The following is a description of a gene set: species: Mus musculus Catalysis of the reactions: D-myo-inositol 1,4,5-trisphosphate + H2O = myo-inositol 1,4-bisphosphate + phosphate, and 1D-myo-inositol 1,3,4,5-tetrakisphosphate + H2O = 1D-myo-inositol 1,3,4-trisphosphate + phosphate. Mouse Gene Set: GOMF_INOSITOL_POLYPHOSPHATE_5_PHOSPHATASE_ACTIVITY, and this is the list of marker genes: Inpp5b (NCBI Gene Id 16330), Synj1, Inpp5j, Inpp5k, Inppl1, Inpp5e, Inpp5a, Inpp5d (inositol polyphosphate-5-phosphatase D), Ocrl, Synj2